Given this list of marker genes SERPINA1, ACTA1 (NCBI Gene Id 58), HLA-B, CXCL9, CYP2E1, IGKV2D-30, ADIPOQ, HLA-DQA2, MPEG1, CDKN1C, IGKC, JCHAIN (NCBI Gene Id 3512), ALB, here is a description of the gene set: Helicobacter pylori infection causes gastric pathology such as ulcer and carcinoma. Because H. pylori is auxotrophic for cholesterol, we have explored the assimilation of cholesterol by H. pylori in infection. Here we show that H. pylori follows a cholesterol gradient and extracts the lipid from plasma membranes of epithelial cells for subsequent glucosylation. Excessive cholesterol promotes phagocytosis of H. pylori by antigen-presenting cells, such as macrophages and dendritic cells, and enhances antigen-specific T cell responses. A cholesterol-rich diet during bacterial challenge leads to T cell-dependent reduction of the H. pylori burden in the stomach. Intrinsic alpha-glucosylation of cholesterol abrogates phagocytosis of H. pylori and subsequent T cell activation. We identify the gene hp0421 as encoding the enzyme cholesterol-alpha-glucosyltransferase responsible for cholesterol glucosylation. Generation of knockout mutants lacking hp0421 corroborates the importance of cholesteryl glucosides for escaping phagocytosis, T cell activation and bacterial clearance in vivo. Thus, we propose a mechanism regulating the host-pathogen interaction whereby glucosylation of a lipid tips the scales towards immune evasion or response. from publication Wunder C, Churin Y, Winau F, Warnecke D, Vieth M, Lindner B, Zähringer U, Mollenkopf HJ, Heinz E, Meyer TF (PMID 16951684) species: Mus musculus Genes down-regulated in gastric mucosal tissue of mice on 2% cholesterol diet and infected with H. pylori vs those infected with H. pylori while on 0% cholesterol diet. Human Gene Set: WUNDER_INFLAMMATORY_RESPONSE_AND_CHOLESTEROL_DN